Given this list of marker genes ARL6IP4, NUBP2 (NUBP iron-sulfur cluster assembly factor 2, cytosolic), TRMT5 (NCBI Gene Id 57570, tRNA methyltransferase 5), ACTR1A, TOMM70, MT1A (metallothionein 1A), LYST, CFAP20, MED7, MAPK11, TMEM81, PLA2G12A, TRPC2, HERC4, CRTAM, SMPD2, PPM1J, MIR29A, ORC1, ANKRD33B, RPL14, CENPI, RNMT, SSH2, GIMAP4, SNRNP70, SNRPC, N4BP2L2, LAGE3, PVR, TBK1, XRN2, ITGB6, EEF1AKMT2, MAD1L1, APOM, RWDD1, PSMA8, BTLA, DKC1, GTPBP4, TLCD4, HNRNPR, DNAJA2, G3BP1, MRPL1, MFN1, ABCF1, PDAP1, VAV1, ITM2A, MIR17HG, ANAPC5, GNRH1, PIGL, CD53, LARP1B (NCBI Gene Id 84199), LRRC14B, GSTA4, DIMT1, TMEM161B, PLK3, SLC25A27 (NCBI Gene Id 9481), RNF138, MPP7, NOP14, WDR12, IFIT3, CHAF1B, PRDX3, KEL, RPL10, YTHDF3, ARHGAP4 (NCBI Gene Id 8275), CLCN7, MAT2A, FLVCR1, ALG5, CCPG1, UBE3D, ARHGDIB, SSU72 (NCBI Gene Id 79588), STAT1, UBR1, ISG20, PAWR, NEMF, ZFP36, KCTD18, COX8A, SH2D2A, RAD51C, AEBP2, ZBTB25, SLC25A33, IL7R, SLC43A3, GZMB, CHKB, TLE1, LDLR, FOXRED1, DBT, FTSJ3, METTL8, FAM174A, ELMO1, BDH1, FBXL3, HDDC2, WDR37, PMM2 (NCBI Gene Id 5373), TRMT10A, TK1, ATF7IP, GTF2H1, RNF128, PIP4K2A, EXTL2, CCL4 (NCBI Gene Id 6351), UTP14A, EIF2S1, LRRC3B, RHAG, INTS9, SS18, TTC28, CALM1, WDR45B, EIF1AX, MX1, PDCD10, GRAMD2B, C9orf78, UBL7, POLG2, HCST, RPS6KB2, XRCC5, AP4E1, ADGRE5, IFNGR1, MIA3, TOM1, MRPL3, SLC20A1, PSMA2, GZMM, CCR7 (NCBI Gene Id 1236), POLR1G, KLHDC8B, H2AZ1, ATG5, NARS2 (asparaginyl-tRNA synthetase 2, mitochondrial), NMI, TMEM186, OLIG3, ARMCX5, DNAJA3, PTPN22, F8A1, IFT57, here is a description of the gene set: IL-10 or IL-6 stimulation of control 129xC57BL/6 murine bone marrow derived macrophages in the presence of LPS. We used microarrays to detail the global programme of gene expression changes in response to IL-6 or IL-10 stimulation in the presence of lipopolysaccharide. BMDMs were isolated from control, IL-6-/-, and IL-10-/- mice on a 129XBL/6 mixed background mice and differentiated in the presence of CSF-1 for 6-7 days. Cells were scraped and plated in 6 well plates at 2x10e6/well. Cells were washed with complete DMEM and rested for 1-2 hr before stimulation with combinations of IL-10 (10 ng/ml), IL-6 (2 ng/ml) or LPS (100 ng/ml) for 45 min or 180 mins. Complete biological replicates were performed. Human Gene Set: GSE5589_WT_VS_IL10_KO_LPS_STIM_MACROPHAGE_180MIN_UP species: Homo sapiens Genes up-regulated in bone marrow-derived macrophages at 180 min of stimulation by LPS: wildtype versus IL10 knockout. from publication El Kasmi KC, Holst J, Coffre M, Mielke L, de Pauw A, Lhocine N, Smith AM, Rutschman R, Kaushal D, Shen Y, Suda T, Donnelly RP, Myers MG Jr, Alexander W, Vignali DA, Watowich SS, Ernst M, Hilton DJ, Murray PJ (PMID 17114459)